The following is a description of a gene set: Human Gene Set: GOBP_PEPTIDYL_LYSINE_MONOMETHYLATION The methylation of peptidyl-lysine to form peptidyl-N6-methyl-L-lysine. species: Homo sapiens, and this is the list of marker genes: KMT5A (lysine methyltransferase 5A), CSKMT, EHMT1, SETD6, SETD7, METTL18, SMYD2